Given this list of marker genes Eny2, Cetn2, Mcm3ap, Pcid2, Cetn3, here is a description of the gene set: studied in species Mus musculus A protein complex that couples SAGA-dependent gene expression to mRNA export at the inner side of the nuclear pore complex (NPC). The TREX-2 complex is tethered to the inner side of the NPC via the nucleoporins Nup1 and Nup60; in S. cerevisiae it contains Sac3p, Thp1p, Sem1, Sus1p and Cdc31p. Mouse Gene Set: GOCC_TRANSCRIPTION_EXPORT_COMPLEX_2